Given this list of marker genes Was, Tjap1 (NCBI Gene Id 74094), Otud7b, Pla2g15, Stk17b, Pkd1, B3gnt9, Osr1, Olfm1, Ripor1, Prrx1 (paired related homeobox 1), Cysltr1, Ccl12, Lsp1, Snx6, Mrc1, Dab2, St3gal2, Clec4a2, Adprh, Arhgef40, Cfl2, Cfp, Sptbn1, Plxnd1, Pofut2, Plekha3, Ccr2, Medag, Dok1, Loxl1, Nbl1, Flnc, St8sia4, Apbb1, Rap1b, Prrx2, Ikbip, Hlx, Apbb2, Phldb1, Fkbp7, Lrp1, Eno3, Ccdc102a, 1810055G02Rik, Rrad, Zfpm2, Fcgr2b, Nrp2, Gpr85 (NCBI Gene Id 72866), C1qtnf6, Pvr, Fxyd5, Fkbp9, Mcub, Jdp2, Mxra8, Traf1, Marveld1 (MARVEL (membrane-associating) domain containing 1), Axl (AXL receptor tyrosine kinase), Sh3glb1, Folr2, Gamt, Ap1s2, F13a1, Scara3, Tspan4, Pdgfra, Plat, Lpar1, Vsig4, Aox1, Matn2, Gpr34, Cfh, Sec23a, Glipr1, Ddr2, Dbn1, Snx20, Adgra2, Sema7a, Nr2f1, Loxl3, Sacs, Gnb4 (NCBI Gene Id 77885), Nrros, Emp3, Fam167b, P3h1, Snx9, Csf1, Hspg2, S100a4, Ttyh2, Rgs18, Cdh13, Itga5, Itgb1bp1, Csf1r, Pcolce, Spi1, Ltc4s, Lamb1, Efemp2, Wnk1, Arl6ip5, Celf4, Fn1, Nfatc1, Epb41l2, Phka1, Ccl9, Gzmg, Naaa, Igfbp4, Fcrl2, Vegfc, Fcgrt, Angptl2, Selenon, Dnm1, Rnf157, Mras, Htra3, Chrna1, Csgalnact2, Zeb1 (zinc finger E-box binding homeobox 1), Vim, Ankrd1, Tgfbr2, Timp2, Dcn, Il18r1, Calu, Hhex, Ehbp1l1, Nek9, Mrc2, here is a description of the gene set: species: Mus musculus from publication Hollern DP, Swiatnicki MR, Andrechek ER (PMID 29346386) Human breast cancer has been characterized by extensive transcriptional heterogeneity, with dominant patterns reflected in the intrinsic subtypes. Mouse models of breast cancer also have heterogeneous transcriptomes and we noted that specific histological subtypes were associated with particular subsets. We hypothesized that unique sets of genes define each tumor histological type across mouse models of breast cancer. Using mouse models that contained both gene expression data and expert pathologist classification of tumor histology on a sample by sample basis, we predicted and validated gene expression signatures for Papillary, EMT, Microacinar and other histological subtypes. These signatures predict known histological events across murine breast cancer models and identify counterparts of mouse mammary tumor types in subtypes of human breast cancer. Importantly, the EMT, Adenomyoepithelial, and Solid signatures were predictive of clinical events in human breast cancer. In addition, a pan-cancer comparison revealed that the histological signatures were active in a variety of human cancers such as lung, oral, and esophageal squamous tumors. Finally, the differentiation status and transcriptional activity implicit within these signatures was identified. These data reveal that within tumor histology groups are unique gene expression profiles of differentiation and pathway activity that stretch well beyond the transgenic initiating events and that have clear applicability to human cancers. As a result, our work provides a predictive resource and insights into possible mechanisms that govern tumor heterogeneity. Genes that are highly expressed in mammary tumors of epithelial-mesenchymal transition (EMT) histology. Mouse Gene Set: HOLLERN_EMT_BREAST_TUMOR_UP